Given this list of marker genes NDUFAF3, ACSL4, BBS10, LHX1, SLX4, DHX16, SOS2, ALG5, GNA11, JAZF1, GRIP1, NOD2, TACR3, CEACAM3, RAP1GDS1, TLR7, BRIP1, SLC25A22, TRPV6 (transient receptor potential cation channel subfamily V member 6), SALL1, ITGB4, PRKACA (protein kinase cAMP-activated catalytic subunit alpha), FANCE, ESCO2, SMOC1, INTU, STAT4, RTTN, RPS28, SGPL1, GNAS, SCAPER, TRIM8, RPGRIP1L, UBE2A, SEMA3A, GAS1, RFX7, MRPS34, SPINT2, GNAO1, MMP23B, CCND1, CASZ1 (castor zinc finger 1), PSMC1, BBS4, ATN1, NCF1, HNF4A, RERE, TXNDC15, MT-ND4, NSDHL, ARX, ATP7A, HPSE2, LRP5, FBN1, RASA2, TP63, PIK3CD, SDHC, BBS12, APC2, SI, DVL1, KCNE5, MKKS, SMC1A, H4C3, CR2, POU3F4, PSMD12, AIP, TRIP11, SASS6, LEMD3, MT-ATP8, KIF14, PPP1R15B, IGHG1, HSD17B4, CLDN2, JMJD1C, VAC14, GLMN, FIG4, HYLS1, MT-CO3 (NCBI Gene Id 4514), ZNF687, MYOD1, BTNL2, CEL, PLEC, FANCD2, IFT43, PPP3CA, NUP37, DCHS1, TMEM218, ZBTB18 (zinc finger and BTB domain containing 18), SMC3, BUB3, C4A, MAP3K7, VDR, MCM7, VPS33B, SLC22A12, PLVAP, LUZP1, SUCLG1, PEX16 (peroxisomal biogenesis factor 16), SLC36A2, WDR62, TLR4, MEFV, SPEN, CFTR, DGKE, WNT3, ANKS6, MFSD2A, TMEM270, SOCS1, PYCR2, MYOCD, NUP107, DNASE1L3, INPP5E, STRA6, NUP133, PIGO, ITGA3, PLD1, TMEM260, MT-ATP6, FUZ, SHPK, SLC26A1, MOCOS, ARID1B, KCNH1, RNU7-1, LZTR1, MT-ND5, FGFR2, RIPK4 (receptor interacting serine/threonine kinase 4), LIG4, GRIN1, REST, ARNT2, MCPH1, RPL26 (NCBI Gene Id 6154), HNRNPH1, CLCNKB, FREM1, SLC5A1, PALB2, BLK, CENPF, MTRR, IFT74, TNFSF4, FAS, IPO8, OTUD5, TRAF3IP1, HLA-B, COLEC10, MRPS22, MT-CO2, TBC1D24, MLXIPL, DYNC2I1 (dynein 2 intermediate chain 1), PMM2, LIMK1, STX1A, CDKN2C, COQ2, ACTG2, RAB3GAP1, PRDM16, RPS15A, AGXT, ENPP1, HAAO, FOXC2, B4GAT1, FAH, TOPORS, B3GLCT, EMP2, CTU2, PKD2, TSC2, CLCNKA, WIPF1, DSE, RAD51C, B2M, PIGQ, ADA, NPHS1, RAD21, LAGE3, NSUN2, ATP5MK, TCTN3, SRCAP, B3GALT6, DMXL2, DZIP1L, NDUFAF6, ADA2, NARS2, KL, TFAP2A, GTF2I, PROK2 (NCBI Gene Id 60675), FOCAD, SIX1, HDAC8, EYA1, UBE2T, KCNJ1, TSR2, ZPR1, MT-TQ, COG1, ITGAM, HLA-DPA1, DBR1, CTLA4, PGM3, TGIF1, TBX18, SLC7A7, TBXT, IFNGR1, KAT5, SF3B2, DLG5, BBS9, COL4A3, SCLT1, ADCY10, DCTN4, CLCN5, RPS20, RPS29, IFT172, ARMC5, PREPL, SARS2, BMP4, GABRD, FKBP6, MT-CO1 (NCBI Gene Id 4512), RAI1, PDCD6IP, ZMYM3, TBC1D8B, ZNFX1, ACTG1, CEP41, EDNRA, APRT, BBIP1, DIS3L2, RAP1B, SLC32A1, PEX26, GEMIN4, TMEM107, FGFR3, RPL27, NSD2, CDKN1C, DPH1, KYNU, HLA-DPB1, FEZF1, LMNA, GNPTAB (NCBI Gene Id 79158), VANGL1, KCNQ1OT1, BUB1B, FKTN, AP2S1, ZFX, PDPN (NCBI Gene Id 29912), MECP2, GFRA1, LRP4, LAMA5, USP9X, SLC35A2, NIPBL, SCN1B (sodium voltage-gated channel beta subunit 1), EBP, FANCM, BRAF, IFT56, SPINK5, GCLC, IL17RD, NXN, PORCN, NPHP4, UMOD, KCNJ5, PIDD1, VPS37D, FLCN, RORA, STX5, TBX3, HS2ST1, WNT5A, PTPRO, PIGV (NCBI Gene Id 55650), BRD4, EPAS1, HSPG2, POLR1A, PEX19, AGTR1, MYRF, CRTAP, YY1, BRCA1 (BRCA1 DNA repair associated), RAF1, LPIN2, OPLAH, CHST14, FKRP, RRAS2, ATP5F1A, SDHA, MIF, MT-ND3, HMGA2, MAX, CEP19, APOB (NCBI Gene Id 338), CFAP418, STK11, INVS, SEMA3E, ARHGDIA, RPL5, ATP6V1E1, PEX11B, WAS, GRHPR, NOP10, CTH, ROBO2 (roundabout guidance receptor 2), FANCG, CDC42BPB, LDLRAP1, KCNAB2, TAF6, GPC4, RAB23 (RAB23, member RAS oncogene family), MME, PRKCZ, SLC2A2, MNX1, HPRT1, G6PC1, RPS26, CRB2, MAGI2, ERBB3, GP1BB, EIF4H, DDX6, USP18, NCAPD3, SDHB, CHD7, SC5D, PDX1, ZNF148, CHN1, GBE1, TMEM127, GRIA3, SPP1, NRIP1, CDKN1A, NOTCH2, SMS, XRCC2, CAPN15 (NCBI Gene Id 6650), NEUROD1, NPHP1, PPM1B, PEX6, NBN, NUP85, TOGARAM1, RSPO2, SLC1A2, INF2, CEP135, PLCE1 (phospholipase C epsilon 1), ALG9, MID1, MT-ND6, KCTD1, HIRA, WASHC5, SLC12A1, CLDN10, SMARCB1, BBS7, PRMT7, TMEM237, RPS27, IFT140, FREM2, FLNB, IRAK1, DYNC2LI1, GDF6, FGF10, ZEB2, RARB, STAG1, PPP2R3C, SRP54, PIK3C2A, LYZ, FGF23, RIT1, FH, BCKDK, IQSEC2, BAZ1B, WNT4, SCARF2, RAB18, DLL4, TMEM231, FANCA, TBL2, ELN, PEX10, DHCR7, EBF3, FOXH1, CD151, ARPC4, TAPBP, NRAS, TGFB1, GTF2IRD1, SMARCC2, GLIS3, APOA1, VPS35L, DUSP6, PRKACB, HESX1, DDX59, SHANK3, MAPKBP1, MTX2, RRAS, PIGT, NADSYN1, PNKP, PACS1, TOR1A, POMT2, H4C5, CEACAM6, RPS24, MT-TW, HNRNPU, STRADA, NUP205, KANK2, ASPM, CDK6, RBBP8, KAT6A, PAX2, B9D2, RPL18 (ribosomal protein L18), WAC (NCBI Gene Id 55468), WBP11, FOXP3, JAK1, HOGA1, FBLN5 (fibulin 5), GPC3, B9D1, ZNF699 (zinc finger protein 699), IARS1, TNXB, TRPC6, ATP1A1, CASP10, PAX1, GP9, KCNJ2, GTF2IRD2, MAPK1, CWC27, EVC, ERI1, LMX1B, KMT2D, HMOX1, SDHAF2, PCK2, ERCC4, CRELD1, AMER1, IFT122, SLC26A9, FAM20A, PROKR2, PEX5, UBE4B, BRF1, AIRE, METTL27, XPNPEP3, ATP7B, FLRT3, LONP1, NEUROD2, PXK, KLRC4, PDHA1, HEATR3, PNPLA2, WFS1, HLA-DRB1, FRAS1, SRRM2, COPB2, MYH11, SMARCA4, TBC1D20, CD81, BSND, KMT2A, FBXL4, SLC6A14, MAB21L1, STX3, AKR1D1, GRM7, NF1, MSH3, SOX9, MYT1L, PEX1, DLK1, GLI3, COQ6, KANSL1, MT-TH (NCBI Gene Id 4564), CAMKMT, PIK3R2, PHEX, WDR11, CIT (NCBI Gene Id 11113), PDCD1, CENPE, GON7, HDAC4, COX14, MOCS1, ALG8, TRRAP (transformation/transcription domain associated protein), RPL35A, ADAT3, MYCN, UBAC2, SLC1A1, EHMT1, LRIG2, DSTYK, CLCN7, MT-TF, PLG, FIBP, MDH2, ARL3, NPHP3, NHERF1, SSR4, AKT1, CLIP2, CREBBP, BNC2, PDE6D, ARID2, PRKAG2, DPH2, GNB1, TRAPPC14, ZMIZ1, NOS1AP, C1QA, RPS17, DNASE2, MDM2, TRIM32, TSC1, ZIC3, COLEC11, AGPAT2, SH2B1, KIRREL1, TBCK, DNAJC21, ARSK, TXNL4A, SLC2A9, RPS19, COG7, ADNP, MED11 (NCBI Gene Id 400569), APOL1, ZAP70, PEX13, ANLN, AHI1, CRIPTO, PGAP2, ITGA6, IRF5, GSTM3 (glutathione S-transferase mu 3), GATA1 (GATA binding protein 1), RPGRIP1, PIGP, NPHS2, PTPN22, MED12 (mediator complex subunit 12), ETFB, NEK8, MRAS, IGF2, LAMA3, COPA, WDR4, WDR35, MT-ND2, IL6, ARVCF, BAP1, JAG1, PIK3CA, BANK1, RET, KCNN4, FANCF, JAM3, FUT8, ATP6V0A4, ZNF423, SLC41A1, FCGR2B, EN1, ETS1, BICC1, SPECC1L, ETFDH, SON, IL12A-AS1, SLC34A1, CCDC141, INSR, TRIP13, CEP290, MOCS2, EVC2, G6PC3, SEC63, NODAL, APPL1, ITGA8, PBX1, COQ8B, TMEM216, FANCI, AVIL (NCBI Gene Id 80056), DNAJC30, BBS2, PRPS1, DEAF1, INS, RBM10, CEP83, DYNC2I2, STIL, MCM5, GRB10, SETBP1, SOX10, GALNT3, RPL31, RNU4ATAC, RBM8A (RNA binding motif protein 8A), SLC7A9, XRCC4, HSPA9, PIGN, MAD2L2, ADAMTSL1, BUD23, PRKCD, ALKBH8, SOX17, MYLK, ROBO1 (NCBI Gene Id 6091), TNIP1, PHC1, POLE, CD96, SLC6A17, LDLR, NUP160, PTPN11, LACC1, RPL8, HFE, SBDS, CLCN3 (chloride voltage-gated channel 3), DPYSL5, NFIA, GNB2, ABCC6, KCNJ11 (NCBI Gene Id 3767), MIA3, ALDH18A1, SKIC3, MED25, FLI1, PGAP3, PTH, CASR, ATP5F1D, VHL, IFNG, PUS3, KIF1B, IFT80 (intraflagellar transport 80), EP300 (NCBI Gene Id 2033), MASP1, FGF17, SIK1, PTH1R (parathyroid hormone 1 receptor), LZTFL1, BSCL2, COMT, CBL, PAH, GLA, DYNC2H1, ANKRD17, ACE, SEC61A1, TMEM138 (NCBI Gene Id 51524), FANCB, SPRED2, WT1, MRPL3, FCGR2A, IL23R, MAP2K1, GAPVD1, HGD, SERPINA1, ACP5, ACTB, NDNF (neuron derived neurotrophic factor), DNASE1, PRTN3, KRAS, CACNA1D, ROR2, ATP6V1B2, SOX11, YRDC, SHOC2, CCNQ, PTCH1, WDR73, MKS1, LIG1, DISP1, DNA2, REN, GSN, TRAPPC10, HSD11B2, ARL6IP6, TBC1D7, LMBRD1, STS (NCBI Gene Id 6802), KDM1A, PKHD1, FLNA, FAT4, SMARCAL1, SKIC2, UFD1, RMND1, H19, C2CD3, PRKCSH, PIGL, CCND2, PGM1, IL12A, HOXD13, THOC6, ZIC2, ATRX, RAB3GAP2, ETFA, KIAA0753, COL4A4, LMNB2, SLC9A3, IL10, SLC12A3, IFT27, CTNS, OSGEP, RAD51, OCRL, TBX15, CEP57, CSPP1, ERAP1, SPRY2, FCGR3B, GP1BA, ABCG8, MAGED2, TMEM67, KCNQ1, COL18A1, VPS33A, DKC1, CILK1, SNRPB, SLC34A3, MT-CYB, KDM6A, HNF1A, CHUK, INTS1, ALPL, RFWD3, GCK, PEX14, FAM149B1 (family with sequence similarity 149 member B1), COL4A1, DDB1, SALL4, ANKFY1, SLC29A3, SF3B4, CLDN19 (claudin 19), RRAGD, SMARCD1, CDON, GATA3, ARL6, SLC25A11, CD2AP, RPL11, FANCC, UBR1, TRIM28, ABCC8, ARPC5, KCNA1, HNRNPK, SLC37A4, SIX5 (NCBI Gene Id 1754), SAA1, BBS1 (NCBI Gene Id 79702), GLIS2, CPT2, CA2, KLF11, CDK5RAP2 (NCBI Gene Id 55755), TREX1, ERCC6, NAA10, MUC1, VPS45, FASLG, WARS1 (NCBI Gene Id 7453), ANKLE2, COQ7, AFF4, ANOS1, MEG3, BUB1, CEP55, RECQL4, KIF7, OXGR1, DPF2, KNSTRN, MYL9 (myosin light chain 9), CLCA4, KNL1, KAT6B, LTBP4, PHGDH, TRNT1, SHH, CHRNA3, RREB1, NUP93, AFF3, KIAA0586, APC, FGF20, CEP63, CTNNB1, TCTN2, PEX12, CCBE1 (collagen and calcium binding EGF domains 1), MLX, ACTN4, BBS5, PPFIBP1, CCDC22, CEP152, CFHR5, XDH, DNMT3A, FLII, ALMS1, BCOR, TNFAIP3, VIPAS39, IDH1, PIGA, SLC34A2, PKD1, PEX3, CDC73, C3, FAN1, PLCD1, ARID1A, ZMYM2, SMARCE1, PUF60, TPRKB, C4B, SCARB2, BRCA2, DAAM2, ITPR1, HNF1B, GLI1, INSL3, NSD1, LARGE1, CHRM3, NLRP3, C1GALT1C1, SIX3, PIGW, CDKN2B, RPL15, BICRA, FGF13, PCSK9 (NCBI Gene Id 50983), YY1AP1, MMP1 (NCBI Gene Id 4312), DYRK1A, SOS1, SLC30A9, DLST, GREB1L, POR, MAFB, MMACHC (metabolism of cobalamin associated C), PAX7, LAMB2, PRKAR1A, PI4KA, MPI, DEPDC5, SPRED1, CC2D2A, WDR19, WNT9B, SLC3A1, SPART, ANTXR1, PIEZO2, PQBP1, NEK1 (NCBI Gene Id 51037), MCTP2, SKI, TBX4, MEN1, ASXL2, DLL1, WBP4 (NCBI Gene Id 11193), TBX22, MYMX, PPP2R1A, WDPCP, GANAB, RTL1, IQCB1, ARHGAP24, COL4A5, MAP2K2, AKT3, MEOX1, KRT17, DCDC2, OFD1, SEC24C, FANCL, STAT1, TULP3, CFH, SUFU, UBE2L3, BMPER, RPL35, PCK1, METTL5, TMCO1 (transmembrane and coiled-coil domains 1), RFC2, CEP164, KIAA0319L, MT-TV, MBTPS2, IL12B, SLC4A1, CAMK2A, BCS1L, USP8, LMOD1, MPDU1 (mannose-P-dolichol utilization defect 1), PIGY, POU6F2, FOXF1 (NCBI Gene Id 2294), NCAPG2, DHCR24, FBXW11, CLPB, CYP24A1, ACVR1, TBX1, AMMECR1, ADAMTS3, ATP5F1E, ATP6V1B1, CASK, FAM20C, CHKA, EXTL3, MYO5B, PRIM1, SDCCAG8, SOX18, TP53RK, SCAF4, MPV17, TAPT1, FGF8, TELO2, MT-ND1, GCM2, ATPAF2, TTC8, FN1, APOE, AGT, TAF13, CDKN1B, CDKL5, DACT1, SPRY4, COG6, CFI, CCR1, POMT1, RPS10, UBA2, PAX4, ERCC8, HRAS, HS6ST1, FGFR1, MYMK, TASP1, H4C9, MYO1E, SCN2A, SERPINH1, PLXNA1, SARS1, GPKOW, POLRMT, GDF3, TTC21B, CDC42, SLC11A1, PEX2, LMNB1, RPS7, ADGRG2, LAMC2, SOX4, MGME1 (NCBI Gene Id 92667), SDHD, CLDN16, ABCG5, SMO, POGZ, CPLANE1, MMUT, ELP1, SRY, SPOP, DCC, COL7A1, RPL9, DICER1, TKT, WNT7B, GLI2, POLR3A, MT-TL1, TCTN1, WLS, DNAJB11, MT-TK, CEP120, FGA, LAMB3, MT-TS2, here is a description of the gene set: Any structural anomaly of the kidney. Abnormal renal morphology Human Gene Set: HP_ABNORMAL_RENAL_MORPHOLOGY species: Homo sapiens